The following is a description of a gene set: Mouse Gene Set: GOBP_REGULATION_OF_COAGULATION studied in species Mus musculus Any process that modulates the frequency, rate or extent of coagulation, the process in which a fluid solution, or part of it, changes into a solid or semisolid mass., and this is the list of marker genes: Hpse, Tmx1, Klkb1, Vkorc1, Kng1, Plau, S100a9, Psg23, Procr, Prkg1 (NCBI Gene Id 381235), Apoe, Cd9, F2, Gp1ba, Hrg, Prkcd, F11, Adamts18, Ephb2, Hs3st5, Fgg, Ubash3b, Thbs1, Angpt1, Tfpi, Adtrp, Fgb, Prdx2, Ano6, Psen2, Apoh, Tspan8, Plaur, Angpt2, Cd36, Cav1, Gp5, Tmprss6, Pdgfa, Serping1, Foxa2, Alox12, F7, Plg, Emilin2, Serpine2, Pdgfra, Tbxa2r, Psen1, Emilin1, F2r, Serpinf2, Pdgfb, Thbd, Proc, Fga, St3gal4, Vwf, Nfe2l2, Ceacam1, Tpsab1, Serpinc1, F2rl1, C1qtnf1, Cpb2, Kng2, Serpine1, Enpp4, Plat, Anxa2, Sh2b3, Vtn, Pros1, Anxa5, F12 (NCBI Gene Id 58992)